The following is a description of a gene set: Human Gene Set: GOMF_ACYLTRANSFERASE_ACTIVITY_TRANSFERRING_GROUPS_OTHER_THAN_AMINO_ACYL_GROUPS Catalysis of the transfer of an acyl group, other than amino-acyl, from one compound (donor) to another (acceptor). species: Homo sapiens, and this is the list of marker genes: GLYATL1, GLYATL3, APOC1, ABHD14B, SIRT3, NAA80, FASN, KAT7, SERINC2, TAF1L, BRPF1, APOA5, AGPAT4, ING3, ATAT1, ALAS2, LPCAT4, ZDHHC19, ZDHHC11, HGSNAT, ACAT1, BRPF3, CDY2B, OSGEPL1, EP300, PAFAH1B2, KAT2A, GPAT2, CLN5, SIRT5, CHAT, HAT1, ACAT2, ZDHHC5, BAZ1A, ELOVL2, LIPT2, NAA10, GCAT, ACAA2, BAAT, ZDHHC2, ZDHHC7, GPAT3, PNPLA4, PLA2G4E, GTF3C4, NCOA3, CERS1, NAA20, NAA11, SIRT4, LPCAT3, MOGAT1, TAF10, ZDHHC3, NAP1L2, NAT10, ZDHHC18, GNPAT, GPAM, DGAT2L6, SIRT2, ALAS1, OSGEP, NAA30, AGPAT1, SAT2, ZDHHC13, NAT9, ZDHHC24, CREBBP, PLAAT3, MCAT, CDY1, ZDHHC12, BCAS3, NAA16, KAT5, SIRT1, CDY1B, SIRT7, BLOC1S1, TADA2A (transcriptional adaptor 2A), KAT6A, USP22, CLOCK, SCP2, PLA2G15, PYGO2, SIRT6, CERS3, SPTLC2 (serine palmitoyltransferase long chain base subunit 2), NAA25, ZDHHC16, ACSM3, CPT1A (carnitine palmitoyltransferase 1A), HHAT, CRAT, AWAT2, PORCN, PLA2G4A, AGPAT2, PDCD5, ELOVL1, NAT1 (NCBI Gene Id 9), PNPLA3, ACSM6, ABHD4, ACSM5, ZDHHC14, SPTSSB, AGPAT3, SPTLC3, LPCAT2, IFNB1, APOA4, CERS6, TAF1, ZDHHC4, NAA60, JADE1, SOAT2, KAT6B, CDY2A, YKT6, GLYATL2, ZDHHC23, SPHK1, ELOVL3, MBOAT2, ZDHHC9, GLYATL1B (glycine-N-acyltransferase like 1B), LRAT (NCBI Gene Id 9227), NAT8, HADHA, ZDHHC15 (zinc finger DHHC-type palmitoyltransferase 15), NAT14, PLAAT1, APOA2, HADHB, CERS4, MOGAT3, MBOAT7, PNPLA2 (NCBI Gene Id 57104), ZDHHC8, MCM3AP, PAFAH1B3, NAT8L, SH3GLB1, MOGAT2, AGPAT5, TMEM68, DBT, DLST, NAT16 (NCBI Gene Id 378154), APOE, NCOA1, ELOVL4, CERS5, NAA50, ING4, GNPNAT1 (NCBI Gene Id 64841), ACSM4, GLYAT, KAT14, SATL1, PAFAH2, ESCO1, GPAT4 (NCBI Gene Id 574440), PLAAT2, MBOAT4, ACSM1, JADE2, ARRB1, FNTA, PNPLA1, ZDHHC21, TLCD3B, SPTSSA, SOAT1, NUPR1, ELOVL6, AANAT, LCAT, ZDHHC17, ZDHHC6, AWAT1, SERINC1, ATF2, ELOVL5, ASPG, TAF9, NAA40, BRCA2, ACSM2A, NAA15, PHF10, PLA2G4C, SRCAP, CROT, TAFAZZIN, DLAT, CRLS1, APOA1, SAT1, NMT1, CPT2 (carnitine palmitoyltransferase 2), CPT1B, ABHD8, GLUL, KAT8, BRD1, ESCO2, MEAF6, ACAA1, CERS2, DGAT2, TGM2, CPT1C, ELOVL7, ACSM2B, OXSM, NAT8B, ZDHHC20, PIGW (NCBI Gene Id 284098), LIPT1, ZDHHC22, LPGAT1, KAT2B, DGAT1, FNTB, PLAAT4, LCLAT1, ABHD5, ZDHHC11B, SPTLC1, GTF2B, SMARCE1, CASD1, NAT2 (NCBI Gene Id 10), MBOAT1, PRDX6, NMT2, PLAAT5, ELP3, ZDHHC1, NAGS, LPCAT1